The following is a description of a gene set: from publication Nikolsky Y, Sviridov E, Yao J, Dosymbekov D, Ustyansky V, Kaznacheev V, Dezso Z, Mulvey L, Macconaill LE, Winckler W, Serebryiskaya T, Nikolskaya T, Polyak K (PMID 19010930) A single cancer cell contains large numbers of genetic alterations that in combination create the malignant phenotype. However, whether amplified and mutated genes form functional and physical interaction networks that could explain the selection for cells with combined alterations is unknown. To investigate this issue, we characterized copy number alterations in 191 breast tumors using dense single nucleotide polymorphism arrays and identified genes with copy number gain organized into 30 amplicons. Amplicons were distributed unequally throughout the genome. Each amplicon had distinct enrichment pattern in pathways, networks, and molecular functions, but genes within individual amplicons did not form coherent functional units. Genes in amplicons included all major tumorigenic pathways and were highly enriched in breast cancer-causative genes. In contrast, genes with somatic mutations in breast cancer were distributed randomly over the genome, did not represent a functionally cohesive gene set, and were relatively less enriched in breast cancer marker genes. Mutated and gained genes did not show statistically significant overlap but were highly synergistic in populating key tumorigenic pathways including transforming growth factor beta, WNT, fibroblast growth factor, and PIP3 signaling. In general, mutated genes were more frequently upstream of gained genes in transcription regulation signaling than vice versa, suggesting that mutated genes are mainly regulators, whereas gained genes are mostly regulated. ESR1 was the major transcription factor regulating amplified but not mutated genes. Our results support the hypothesis that multiple genetic events, including copy number gains and somatic mutations, are necessary for establishing the malignant cell phenotype. Human Gene Set: NIKOLSKY_BREAST_CANCER_16Q24_AMPLICON species: Homo sapiens Genes within amplicon 16q24 identified in a copy number alterations study of 191 breast tumor samples., and this is the list of marker genes: TUBB3, MC1R, IL17C, PIEZO1, TRAPPC2L, APRT, COX4I1, GAS8-AS1, VPS9D1, CDK10, ACSF3, CHMP1A, SLC7A5, ZNF778, SNAI3, SPATA33, GAS8, RNF166, EMC8, ZFPM1, CDT1, ANKRD11, MAP1LC3B, ZNF276, DPEP1, CYBA, PABPN1L, SPATA2L, SPG7, DEF8, SPIRE2, FANCA, JPH3, GALNS, TCF25, DBNDD1, C16orf74, GINS2 (NCBI Gene Id 51659), BANP, CPNE7, RPL13 (NCBI Gene Id 6137), CA5A, GSE1, CENPBD1P, PRDM7, MVD, ZCCHC14, ZC3H18, KLHDC4, CBFA2T3, CTU2, CDH15